The following is a description of a gene set: The process in which a relatively unspecialized cell acquires the specialized features of a mesoderm cell. species: Mus musculus Mouse Gene Set: GOBP_MESODERMAL_CELL_DIFFERENTIATION, and this is the list of marker genes: Foxc2, Etv2, Taf10, Pou5f1, Fgfr1, Sfrp2, Nanog, Wnt3a, Tal1, Six2, Inhba, Kdm6a, Smad1, Itgb1, Itgb3, Itgb4, Foxf1, Nodal (NCBI Gene Id 21792), Dkk1, Itga3, Mesp1, Itga8, Ext1, Pax2, Hoxa11, Bmp4, Hmga2, Tbx6, Itga2, Gja1, Eya1, Kdm6b, Bmpr1a